Given this list of marker genes PID1, MT-ND6, PRKN, ALDOA, ATP5F1E, MT-ATP6, NDUFS2, NDUFA2, VCP, ADCY10, NDUFS1, NDUFB3, SLC25A13, LDHC, NDUFA10, MT-ND4L, ATP5F1C, ATP5F1EP2, NDUFB11 (NADH:ubiquinone oxidoreductase subunit B11), COX11, NUDT2, SDHB, NDUFA1, ATP5MF, NDUFB7, NDUFA12, ATP5MC1, NDUFA13, MT-ND4, NDUFV3, UQCC3, NDUFA7, ATPSCKMT, ANTKMT, ATP5MG, NDUFA5, NDUFS6, PARP1, MT-ND5, ENO1 (NCBI Gene Id 81977), VPS9D1, ATP5PB, NDUFB8, ATP5MC3, NDUFB2, NDUFS5, SDHA, DNAJC30, DMAC2L, ATP5PD, SPHK2, SDHC (succinate dehydrogenase complex subunit C), NDUFA6, TGFB1, NDUFC2, MT-ND2, ATP5MGL, TAFAZZIN, MT-ND3, TREM2, STAT3, MAP2K1, PRKAG2, NDUFS3, ATP5F1D, TMSB4X, ATP5PF, MT-ATP8, NDUFB1, ATP5MK, NDUFB9, LETMD1, STOML2, NDUFS7, PPARA, ATP5F1B, NDUFB5, ATP5F1A, PINK1, NDUFS8, ATP5MC2, IL4, SDHD, NDUFB10, ATP5MJ, ATP6V0C, ATP5PO, FAM3A (FAM3 metabolism regulating signaling molecule A), NDUFB4, NDUFA3, MIR675, NDUFA11, NDUFA8, NDUFV2, MT-ND1, NDUFC1, NDUFA9, NDUFB6, LIPA (lipase A, lysosomal acid type), ATP5IF1, NDUFS4, NDUFAB1, NDUFV1, ATP5ME, here is a description of the gene set: The chemical reactions and pathways resulting in the formation of ATP, adenosine 5'-triphosphate, a universally important coenzyme and enzyme regulator. studied in species Homo sapiens Human Gene Set: GOBP_ATP_BIOSYNTHETIC_PROCESS